The following is a description of a gene set: Human Gene Set: GSE16522_MEMORY_VS_NAIVE_ANTI_CD3CD28_STIM_CD8_TCELL_DN species: Homo sapiens from publication Hinrichs CS, Borman ZA, Cassard L, Gattinoni L, Spolski R, Yu Z, Sanchez-Perez L, Muranski P, Kern SJ, Logun C, Palmer DC, Ji Y, Reger RN, Leonard WJ, Danner RL, Rosenberg SA, Restifo NP (PMID 19805141) Effector cells for adoptive immunotherapy can be generated by in vitro stimulation of naïve or memory subsets of CD8+ T cells. While the characteristics of CD8+ T cell subsets are well defined, the heritable influence of those populations on their effector cell progeny is not well understood. We studied effector cells generated from naïve or central memory CD8+ T cells and found that they retained distinct gene expression signatures and developmental programs. Effector cells derived from central memory cells tended to retain their CD62L+ phenotype, but also to acquire KLRG1, an indicator of cellular senescence. In contrast, the effector cell progeny of naïve cells displayed reduced terminal differentiation, and, following infusion, they displayed greater expansion, cytokine production, and tumor destruction. These data indicate that effector cells retain a gene expression imprint conferred by their naïve or central memory progenitors, and they suggest a strategy for enhancing cancer immunotherapy. Genes down-regulated in comparison of stimulated memory CD8 T cells from pmel-1 mice versus stimulated naive CD8 T cells from pmel-1 mice., and this is the list of marker genes: CNN3, INSL6, CAMK1D, TRIB2, PTDSS2, CXXC5, IL2RG, CDIP1, CPSF4, PLCG1, IPO5, CD86, TNFRSF18, TESC, CD160, RIMKLA, PSMB9, CTDNEP1, ZNF862, SLAMF1, RNF213, ARFGAP2, GNA13, NDST1, ZBP1, SMG5, RFWD3, TMTC4, NDRG1, FASLG, SOCS2, HIRIP3, CDCA5, TNFRSF4, EPCAM, CD8A, CASP7, NRN1, GNB5, INTS11, N4BP2, DHX34, ACTN2, CTSS, RNF4, SLC29A1, ASF1A, GBP6, LRFN5, CD74, LRWD1, PSMB10, CD200, GGT1, CNKSR3, CCT2, ITGAE, IL18BP, GSTT2, TBKBP1, CDYL2, PLCB4, SLC15A3, N4BP1, HSD11B1, LAG3, ATP5F1B, IL12RB1, CELF1, UBE2L6, MAP4K1, AGPAT3, ETV6, FUT8, ABCG1, CD2, CD9, IL21, ECHDC2, NRGN, CASP4, NMT1, SLC25A17, ISG20, NASP, PTPRK, IFT25, DDX11, VRK1, UTP3 (NCBI Gene Id 57050), SCNN1G, AGPAT4, FAM3C, IRGM, HLA-DOA, STK38L, AMZ2, SF3A3, HVCN1, GJB2, PRKCA, MED30, ITGB7, RFX5, MPZL2, SDF4, RABGGTA, FBF1, ADD3, IFI27, IFIT1, SPIN1, AGFG1, PRDX1, SUV39H1, IL1R2, CTSZ, MYL10, EGLN3, PLK2, ESAM, HSH2D (NCBI Gene Id 84941), IDH2, LIMD2, CD8B, ABCF1, AHR, GBP2, CD247, VSTM4, IL10, SMPDL3A, HLA-DMA, GM2A, MARCKSL1, DCAF1, GABARAPL1, WLS, AHI1, KLHDC3, PDZK1IP1, HLA-G, BEND5, IRF7, GPRASP2, ERAS, MTMR4, ADSS2, OAS1, COL22A1, ALDH2, UBAC1, NCF1 (neutrophil cytosolic factor 1), CCND2, SAMHD1, MINDY3 (NCBI Gene Id 80013), C5orf34, SCN1B, XDH, TREML2, NDUFS7, LGALS9B, PDCD1, MGST2, LONRF3, IFI27L2, ZDHHC22, LGALS3BP, LYAR, RFC1, PTPN1, ADA, EPS15, LAT, PTGFRN, STAT1, TLCD1, ABCA3, BMS1, HNRNPLL, HAT1, CNOT11, C2CD4B, IRF1, BCL11B, FAM241A, OAF, CHCHD10, CDK2, SHMT2, NIT1, STX12, FOS, EIF3C, CASP1, RRP1B, CSRP1, ATP10D, HNRNPA1, CDK5RAP3